The following is a description of a gene set: A supramolecular fiber containing myosin heavy chains, plus associated light chains and other proteins, in which the myosin heavy chains are arranged into a filament. studied in species Homo sapiens Human Gene Set: GOCC_MYOSIN_FILAMENT, and this is the list of marker genes: MYH3, MYOM2, MYH4, MYBPC3, MYH7B, MYO18B, MYH15, MYBPH (myosin binding protein H), MYH9, MYBPC1, TRIM32, MYH6, MYH14, MYOM1, MYH8, MYO18A, MYH11 (NCBI Gene Id 4629), ACTG2, MYBPC2, MYH2, MYH10, MYH1, MYH13, MYH7